The following is a description of a gene set: studied in species Homo sapiens part of: Generic Transcription Pathway The VENTX (also known as VENT homeobox or VENTX2) gene is a member of the homeobox family of transcription factors. The ortholog of VENTX was first described in Xenopus where it participates in BMP and Nanog signaling pathways and controls dorsoventral mesoderm patterning. The zebrafish ortholog of VENTX is also involved in dorsoventral patterning in the early embryo. Rodents lack the VENTX ortholog. VENTX is expressed in human blood cells and appears to play an important role in hematopoiesis. The role of VENTX in hematopoiesis was first suggested based on its role in mesoderm patterning in Xenopus and zebrafish. VENTX promotes cell cycle arrest and differentiation of hematopoietic stem cells and/or progenitor cells (Wu, Gao, Ke, Giese and Zhu 2011, Wu et al. 2014). Ventx suppression leads to expansion of hematopoietic stem cells and multi-progenitor cells (Gao et, J. Biol.Chem, 2012). VENTX induces transcription of cell cycle inhibitors TP53 (p53) and p16INK4A and activates tumor suppressor pathways regulated by TP53 and p16INK4A (Wu, Gao, Ke, Hager et al. 2011), as well as macrophage colony stimulating factor receptor (CSF1R) (Wu, Gao, Ke, Giese and Zhu 2011) and inhibits transcription of cyclin D1 (CCND1) and Interleukin-6 (IL6). Chromatin immunoprecipitation showed that EGR3 transcription factor directly binds to the promoter of IL6 and IL8 genes (Baron VT et al, BJC 2015). While VENTX expression may suppress lymphocytic leukemia, high levels of VENTX have been reported in acute myeloid leukemia cells, with a positive effect on their proliferation. Another homeobox transcription factor that regulates differentiation of hematopoietic stemm cells is DLX4. Studies on colon cancer showed that VentX regulates tumor associated macrophages and reverts immune suppression in tumor microenvironment. MEK1 is required for Xenopus Ventx2 asymmetric distribution during blastula cell division. Ventx2 inhibition by MEK1 is required for embryonic cell commitment (Scerbo et al, eLife, 2017). VENTX induces TP53-independent apoptosis in cancer cells (Gao H, Oncotarget, 2016). During Xenopus embryonic development, VENTX ortholog regulates transcription of the sox3 gene as well as the early neuronal gene zic3. Reactome Pathway: Transcriptional Regulation by VENTX, and this is the list of marker genes: CDKN2A, ANAPC11, MIR24-2, CDC23, MOV10, RELA, ANAPC2, TCF7L2, ANAPC4, ANAPC5, CDC26, EHMT2, CCND1, UBE2D1, ANAPC1, VENTX, AGO3, TNRC6A, UBE2S, UBE2C, ANAPC7, CTNNB1, CEBPB, ANAPC10, IL6 (interleukin 6), AGO1, UBE2E1, LEF1, CDC16, NFKB1, ANAPC15, TNRC6B, AGO4, TP53, FZR1, CDC27, TNRC6C, MIR24-1, ANAPC16, CSF1R, EHMT1